Given this list of marker genes MTOR, MAPKAP1, TFEB, ULK1, PIK3R2, TSC2, PIK3R1, RICTOR (NCBI Gene Id 253260), FOXO4, NOS3, PIK3CA, ATG13, GSK3B, CDKN1B, PIK3CG, EIF4EBP1, PIK3CB, FOXO1, AKT1, NRAS, RB1CC1, KRAS, MLST8, PIK3R3, GRB10 (growth factor receptor bound protein 10), PDK1, HRAS, BAD, RHEB, RPTOR, FOXO3, PTEN, here is a description of the gene set: PI3K-AKT-mTOR signaling and therapeutic opportunities in prostate cancer Human Gene Set: WP_PI3KAKTMTOR_SIGNALING_AND_THERAPEUTIC_OPPORTUNITIES_IN_PROSTATE_CANCER studied in species Homo sapiens